The following is a description of a gene set: The immune responses generated by YF-17D by profiling genes in 25 vaccine recipients were accessed at days 1, 3, 7, and 21 post-vaccination compared to pre-vaccination in PBMCs. The immune responses generated by YF-17D by profiling genes in 25 vaccine recipients were accessed at days 1, 3, 7, and 21 post-vaccination compared to pre-vaccination in PBMCs. studied in species Homo sapiens Human Gene Set: GSE13485_DAY1_VS_DAY7_YF17D_VACCINE_PBMC_UP Genes up-regulated in comparison of unstimulated peripheral blood mononuclear cells (PBMC) 1 day after stimulation with YF17D vaccine versus PBMC 7 days after the stimulation. from publication Querec TD, Akondy RS, Lee EK, Cao W, Nakaya HI, Teuwen D, Pirani A, Gernert K, Deng J, Marzolf B, Kennedy K, Wu H, Bennouna S, Oluoch H, Miller J, Vencio RZ, Mulligan M, Aderem A, Ahmed R, Pulendran B (PMID 19029902), and this is the list of marker genes: HAP1, GPR50 (NCBI Gene Id 9248), FAM78B, CCDC116, NKAIN4, LINC01366, CCDC60, MMP28, RSU1P2, WFDC1, OXER1, OMD, EEF1G, SCG2, IL11, SMR3B, MRAP2, SLC17A7, FRMD1, MME, CAMK2A, SEC16B, KIF12, GDA, AGRP, ESR2, LINC03066, ENSG00000224715, IFNA4, ADAMTS4, CSH1, LY6G6E, MADCAM1, MYOZ3, LINC00929, ELFN2 (NCBI Gene Id 729481), RIBC2, WDR72, PROM2, SDK2, HTR3C, AQP4-AS1, LINC01512, FKBP6P2, RYR2, LINC00520, ENSG00000176984 (novel transcript, antisense to TRIM29), KRTAP4-12, TNFSF18, MAB21L4, TRPM3, MAPK8IP2, GARIN2, TIMM23B, THY1, FTCD, ASB10, OR8D2, LINC02043, SIGLECL1, SYNPO2L, SGSH, ITGAE, HOXD3, PTPRT, APLNR, CFAP157, OR1C1, CDON, S100A16, GLRA2, EIF4B, CCN1, LAMC2, KLC3, P2RY4, SALL3, ADAMTS9-AS2, IFNA17, RDH8, DCST1, CHRNA4, OR7E104P, RPL3, OR51J1, HOXB13, SUSD2, PAX9, TRIM67, OR2A4, ADAD1, GUSBP2, RPS6KA6, OVOL3, LSAMP-AS1, SMOC2, DIO2, SLC4A8, CSPG4P5, MEP1B, UBTF, NKAIN3, PPIC, ARC, MYBPH, CA8, ST3GAL3, RFLNA, MMP2, ATP6AP1-DT, SLC22A8, ACOT11, GPR3 (NCBI Gene Id 2827), ERVV-1, KIAA1614, ITGB6, PKD1L2, CHST4, KCNH4, PHOX2B, ZNF491 (zinc finger protein 491), BCL9L, SPATA19, KIF1A, GSTA3, PRDM10-DT, GFAP (glial fibrillary acidic protein), RBM20, TAS2R7, EPS8L3, TEX22, DNTT, PPP1R1B, CNTN2, PCDHGB7, TTLL10, IL17RC, KCNA4, MRGPRX4, RNASE11-AS1, VWA3A, SPATA24, DIPK2B, OLFM2, JRK, ENSG00000235143, HTR1E, KRTAP3-1, SPEG, LINC01785, MAJIN, GML, CDH26, CCNT1, SLC17A1, CLDN2, FBLN1, LMX1A, RAMP3, LINC00265, ARHGEF39, PI15, WFDC2, ID4, GPR26, GRHL2, NBPF4, LINC02907, LINC00928, PANX2, GNAT1, SPAM1, ZNF740, EEF1D, INE1, LINC00652, SH2D4A, ABCB5, ASB15, DUSP19, GRIK1-AS1, SPRR2G, ETFBKMT, C9orf163 (NCBI Gene Id 158055), CYGB